The following is a description of a gene set: Binding to a basal RNA polymerase II transcription factor, any of the factors involved in formation of the preinitiation complex (PIC) by RNA polymerase II and defined as a basal or general transcription factor. studied in species Mus musculus Mouse Gene Set: GOMF_RNA_POLYMERASE_II_GENERAL_TRANSCRIPTION_INITIATION_FACTOR_BINDING, and this is the list of marker genes: Fbl, Ercc4, Foxf2, Gtf2e2, Drap1, Ar (androgen receptor), Taf7, Nolc1, Edf1, Crebbp, Ctdp1, Ercc1, Trp53, Ahr, Ruvbl1, Gtf2a1, Taf1, Znhit6, Hnrnpu, Ruvbl2, Nop58, Esr1, Gtf2f1, Gtf2a2, Tbp, Tcf4